The following is a description of a gene set: Any process that activates or increases the frequency, rate, or extent of granulocyte macrophage colony-stimulating factor production. species: Mus musculus Mouse Gene Set: GOBP_POSITIVE_REGULATION_OF_GRANULOCYTE_MACROPHAGE_COLONY_STIMULATING_FACTOR_PRODUCTION, and this is the list of marker genes: Fcer1a, Il12b, Il23a, Rigi, Il18, Il17d, Card9, Il1b, Isl1, Rasgrp1, Tlr9, Syk